The following is a description of a gene set: The FGFR3 gene has been shown to be subject to activating mutations and gene amplification leading to a variety of proliferative and developmental disorders depending on whether these events occur in the germline or arise somatically. <br><br>Activating mutations in FGFR3 are associated with the development of a range of skeletal dysplasias that result in dwarfism. The most common form of human dwarfism is achondroplasia (ACH), which is caused by mutations G380R and G375C in the transmembrane domain of FGFR3 that are thought to promote ligand-independent dimerization Hypochondroplasia (HCH) is a milder form dwarfism that is the result of mutations in the tyrosine kinase domain of FGFR3. Two neonatal lethal conditions, thanatophoric dysplasia type I and II (TDI and TDII) are also the result of mutations in FGFR3; TDI arises from a range of mutations that either result in the formation of unpaired cysteine residues in the extracellular region that promote aberrant ligand-independent dimerization or by mutations that introduce stop codons. A single mutation, K650E in the second tyrosine kinase domain of FGFR3 is responsible for all identified cases of TDII. Other missense mutations at the same K650 residue give rise to Severe Achondroplasia with Developmental Disorders and Acanthosis Nigricans (SADDAN) syndrome. The severity of the phenotype arising from many of the activating FGFR3 mutations has recently been shown to correlate with the extent to which the mutations activate the receptor <br><br>In addition to mutations that cause dwarfism syndromes, a Pro250Arg mutation in the conserved dipeptide between the IgII and IgIII domains has been identified in an atypical craniosynostosis condition. This mutation, which is paralogous to mutations seen in FGFR1 and 2 in Pfeiffer and Apert Syndrome, respectively, results in an increase in ligand-binding affinity for the receptor.<br><br><br>Of all the FGF receptors, FGFR3 has perhaps the best established link to the development in cancer. 50% of bladder cancers have somatic mutations in the coding sequence of FGFR3; of these, more than half occur in the extracellular region at a single position (S249C). Activating mutations are also seen in the juxta- and trans-membrane domains, as well as in the kinase domain. As is the case for the other receptors, many of the activating mutations that are seen in FGFR3-related cancers mimic the germline FGFR3 mutations that give rise to autosomal skeletal disorders and include both ligand-dependent and independent mechanisms. In addition to activating mutations, the FGFR3 gene is subject to a translocation event in 15% of multiple myelomas. This chromosomal rearrangement puts the FGFR3 gene under the control of the highly active IGH promoter and promotes overexpression and constitutive activation of FGFR3. In a small proportion of multiple myelomas, the translocation event is accompanied by activating mutations in the FGFR3 coding sequence.<br><br>More recently, a number of fusion proteins of FGFR3 have been identified in various cancers. The most common fusion protein is TACC3, a coiled coil protein involved in mitotic spindle assembly. FGFR3 fusion proteins are constitutively active and appear to contribute to proliferation and tumorigenesis through activation of the ERK and AKT signaling pathways. Reactome Pathway: Signaling by FGFR3 in disease part of: Signaling by FGFR in disease studied in species Homo sapiens, and this is the list of marker genes: FRS2, FGF18, FGF9, FGF2, FGF1, FGF5 (fibroblast growth factor 5), KRAS, PIK3R1, FGF4, FGF20, GRB2, FGFR3 (fibroblast growth factor receptor 3), FGF23, GAB1, FGF17, NRAS, PLCG1, FGF16, PIK3CA, HRAS, SOS1, FGF8